Given this list of marker genes LDLRAP1, MIR27B, DGAT2, KPNB1, AQP8, ABCG1, SREBF2, ABCG4, NR1H4, DGKQ, ARV1, LMF1, MIR98, APOE, TTC39B, GNAI1, INSIG1, GPR146, C7orf50, APOA1, ABCA2, ERLIN1, MIR96, ERLIN2, CH25H, CES1, MBTPS2, AGT, CYP7A1, LDLR, FGF1, PAQR3, ACADL, MBTPS1, LPCAT3, FMO5, SERPINA12, MIR182, GNB3, SCAP, MIR548P, MIR27A, AGTR1, APOB, MIR185, QKI, ACADVL, PRKAA1, MIR342, MAPK1, MIR30C1, SREBF1, STARD4, PRKACA, SEC14L2, EPHX2 (epoxide hydrolase 2), here is a description of the gene set: Any process that modulates the rate, frequency, or extent of cholesterol metabolism, the chemical reactions and pathways involving cholesterol, cholest-5-en-3 beta-ol, the principal sterol of vertebrates and the precursor of many steroids, including bile acids and steroid hormones. studied in species Homo sapiens Human Gene Set: GOBP_REGULATION_OF_CHOLESTEROL_METABOLIC_PROCESS